The following is a description of a gene set: Human Gene Set: HP_ABNORMAL_GALLBLADDER_MORPHOLOGY studied in species Homo sapiens Abnormal gallbladder morphology A structural anomaly of the gallbladder., and this is the list of marker genes: PFKM, GTF2IRD1, KCNN4, GP1BB, SON, CNOT1 (NCBI Gene Id 51579), COMT, GBA1, BUD23 (BUD23 rRNA methyltransferase and ribosome maturation factor), BLVRA (NCBI Gene Id 644), PIEZO1, SCARB2, VPS37D, LIMK1, SEC24C, PSAP, AMACR, ALAS2, METTL27, MRPL39, KDM5C, SMPD1, AIRE, FKBP6, PEX19, TMEM270, SPTA1, FECH, STX1A, ATP8B1, TBX1, VPS4A, B3GLCT, HIRA, TBL2, CYP27A1, SCNN1G, ARSA, GNE (NCBI Gene Id 81868), SEMA4D, NCF1, GPR35, ALDOA, GCGR, ELN, SLC4A1, SC5D, MED25 (mediator complex subunit 25), CYP7A1, CC2D2A, UFD1, RFX6, SCNN1A, GTF2IRD2 (GTF2I repeat domain containing 2), PKLR, SCNN1B, PKHD1, TCF4, INTU, FOXF1, GATA6, GPI, UROS, UQCRFS1, BAZ1B, ASXL1, CLIP2 (CAP-Gly domain containing linker protein 2), HK1, RREB1, DNAJC30, ITPR1, GYPC, SEC23B, JMJD1C, MST1, ABCG8, DMPK, ARVCF, EPB41, HGD, ABCB11, EPB42, HBB, ABCB4, TFE3, GPR101, GTF2I, AIP, MPV17, CCDC47, RFC2, TPI1, ANK1, EIF4H, SPTB